The following is a description of a gene set: part of: Metabolic disorders of biological oxidation enzymes Reactome Pathway: Defective CYP26B1 causes RHFCA Retinoic acid (RA) is a biologically active analogue of vitamin A (retinol). RA plays an important role in regulating cell growth and differentiation.CYP26A1 and B1 are involved in the metabolic breakdown of RA by 4-hydroxylation. High expression levels of CYP26B1 in the cerebellum and pons of human brain suggests a protective role of specific tissues against retinoid damage. Defects in CYP26B1 can cause radiohumeral fusions with other skeletal and craniofacial anomalies (RHFCA; MIM:614416), a disease characterised by craniofacial malformations and multiple skeletal anomalies. species: Homo sapiens, and this is the list of marker genes: CYP26B1